Given this list of marker genes Psmc5, Psma4, Relb, Nfkb2, Map3k14, Psmc2 (NCBI Gene Id 19181), Rps27a, Psmc6, Psmb7, Psmd7, Psma6, Psmb5, Psmd13, Psmc1, Psma1, Psmd12, Psma2, Psmc4, Cul1, Psmb6, Psma3, Psma5, Psma7, Ubb, Psmd6, Psmd1 (proteasome (prosome, macropain) 26S subunit, non-ATPase, 1), Psmb4, Psmc3, here is a description of the gene set: This event has been computationally inferred from an event that has been demonstrated in another species.<p>The inference is based on the homology mapping from PANTHER. Briefly, reactions for which all involved PhysicalEntities (in input, output and catalyst) have a mapped orthologue/paralogue (for complexes at least 75% of components must have a mapping) are inferred to the other species. Reactome Pathway: NIK-->noncanonical NF-kB signaling studied in species Mus musculus electronically inferred by orthology from the curated human pathway part of: TNFR2 non-canonical NF-kB pathway